The following is a description of a gene set: The process in which a precursor cell type acquires characteristics of a more mature T-cell. A T cell is a type of lymphocyte whose definin characteristic is the expression of a T cell receptor complex. Mouse Gene Set: GOBP_T_CELL_DIFFERENTIATION studied in species Mus musculus, and this is the list of marker genes: Sos2, Ikzf3, Tsc1, Ptprc, Bmp4, Gata3, Ikzf1, Runx2, Mdk, Lgals1, Hlx, Atg5, Lag3, Tmem98, Foxp3, Carmil2, Tcf3, Zfp36l2, Pla2g2d, Ctla2a, Rps6, Runx3, Tnfrsf9 (tumor necrosis factor receptor superfamily, member 9), Smarca4, Il18, Prkdc, Pax1, Txk, Kdelr1, Ifng, Klhl25, Psap, Mir326, Itgb8, Foxj1, Braf (NCBI Gene Id 97330), Vsir (NCBI Gene Id 74048), Btnl1, Il7, Stat4, Cd83, Jak3, Tespa1, Tgfbr2, Fadd, Cd8a, Zbtb7b, Mafb, H2-M3, Xbp1, Rpl22, Il18r1, Cacnb4, Ep300, Kat2a, Kctd9, Slc46a2, Pbrm1, Clec4d, Sp3, Vav1, Il21, Armc5, Dll4, Rhoh, Drosha, Hmgb1, Egr3, Relb, Stat6, Il1b, Gimap5, Apc, Wnt4, Il6, Ppp3cb, Brd4, Shh, Spi1, Ap3d1, Cdkn2a, Il4i1, Smarcd2, Lipa, Lig4, Pik3r6, Sox4, Ripk2, Duxbl1, Il12b, Gpr89, Foxp1, Ifnar2, Cbfb, Il23a (interleukin 23, alpha subunit p19), Brd7, Sox13, Igtp, Rc3h2, Bcl11b, Jmjd6, Prdm1, Stat5a (signal transducer and activator of transcription 5A), Itpripl1, Foxo3, Sema4a, Lilrb4b, Ripk3, Fancd2, Myb, Lmbr1l, Socs1, Fosl2, Kat5, Aire, Nlrp3, Gba1, Shb, Kat7, Arid1a, Ccl19, Cd27, Il27, Tbk1, Atf2, Nfkbid (NCBI Gene Id 243910), Mr1, Il1a, Clec4g, Prex1, Rhoa, Entpd7, Ctnnb1, Nkap, Zc3h8, Smarce1, Tbx21, Dnaja3, Dicer1, Irf1, Nkx2-3, Lep (NCBI Gene Id 16846), Itgb6, Cd3d, Zfp609, Ptpn2, Zfp608, Slamf6, Wnt10b, Hspb1, Btn2a2, Phf10, Loxl3, Abl1, Ccr9, Wnt1, Gpr18 (NCBI Gene Id 263515), Fzd8, Trp53, Mpzl2, Mir873a, Ctsl, Nfkbiz, Flt3, Smarcd3, Rorc, Nhej1, Prdx2, Wwp1, Zbtb1, Zfp36l1, Itpkb, Cdk6, Rc3h1, Fgl2, Lepr, Mtor, Otud5, Bcl3, Vnn1, Satb1 (NCBI Gene Id 70334), Cracr2a, Tnfsf9, Ly9 (lymphocyte antigen 9), Arid2, Actb, H2-Oa, Tox, Il4ra, Usp44, Batf, Ascl2, Cd74, Adam17, Kcnk18, Themis, Itk, Pck1 (phosphoenolpyruvate carboxykinase 1, cytosolic), Traf3ip2, Rag2, Zmiz1, Il2ra, Pik3r1, Il12a, Rara, Sh3rf1, Cyld, Prkcz, Nckap1l, Xrcc4, Rsad2, Hs1bp3, Stat3, Smarcc1, Sh2b3, Fas, Card11, Stat5b, Tcf7, Ccr7, Ptger4 (prostaglandin E receptor 4 (subtype EP4)), Zeb1, Pf4, Sart1, Zap70, Bcl2, Ap3b1, Cd1d1, Dock2 (NCBI Gene Id 94176), Scart2, H2-Ea, Kmt2a, Slc4a2, Sox12, Bmi1, Zc3h12a, Psmb11, Cd28, Lck, Ccl20, Lilrb4a, Foxn1, Smad7, Gpr183, Cd46, B2m, Mettl3, Zfp683, Prelid1, Ccr2, Nrarp, Ambra1, Runx1, Il6ra, Lgals9, Tnfsf18, Fzd7, Bcl2a1d, Cd3e, Kit, Enpp1, Srf, Tcirg1, Cd3g, Fzd5, Dtx1, Bcl11a, Malt1, Sos1, Gli3 (NCBI Gene Id 14634), Rag1 (NCBI Gene Id 19373), Mir301, Tgfb1, H2-DMa, Lfng, Cd69, Spn, Hsp90aa1, Cyp26b1, Cd4, Skint1, Cd44 (NCBI Gene Id 99339), Socs5, Lef1, Blm (Bloom syndrome, RecQ like helicase), Clptm1, Bcl6, Anxa1, Adrm1, Prr7, Ifnb1, Bad, Hotairm1, Tmem131l, Smarcd1, H2-Aa, Brd2 (NCBI Gene Id 547337), Btnl6, Zfp35, Egr1, Men1, Ptcra, Ncaph2, Opa1, Gadd45g, Il15, Stk11, Rasgrp1, Adam8, Gimap1, Crtam, Syk, Ccr6, Muc19, Tnfsf4, Il2rg, Pknox1, Hmga1, Ada, Il4, Il2, Irf4, Actl6b, Ihh, Fut7, Ankle1, Pnp, Ncor1, Rora (RAR-related orphan receptor alpha), Tnfsf8, Smarcc2, Fanca, Clec4e, Il1rl2, Patz1, Ptpn22, Il36b, Smarca2, Smarcb1, Fcer1g (NCBI Gene Id 98395), Traj18, Actl6a (actin-like 6A), Eomes, Dusp10, Rabl3, Jag2, Gimap3, Mink1, Il7r, Chd7, Erbb2, Ctla4, Abl2, Sash3, Nfatc3, Atp7a